Given this list of marker genes PAX6, MSX1, DCX, ZIC1, TUBB3, here is a description of the gene set: Human Gene Set: TESAR_ALK_AND_JAK_TARGETS_MOUSE_ES_D4_UP studied in species Mus musculus The application of human embryonic stem (ES) cells in medicine and biology has an inherent reliance on understanding the starting cell population. Human ES cells differ from mouse ES cells and the specific embryonic origin of both cell types is unclear. Previous work suggested that mouse ES cells could only be obtained from the embryo before implantation in the uterus. Here we show that cell lines can be derived from the epiblast, a tissue of the post-implantation embryo that generates the embryo proper. These cells, which we refer to as EpiSCs (post-implantation epiblast-derived stem cells), express transcription factors known to regulate pluripotency, maintain their genomic integrity, and robustly differentiate into the major somatic cell types as well as primordial germ cells. The EpiSC lines are distinct from mouse ES cells in their epigenetic state and the signals controlling their differentiation. Furthermore, EpiSC and human ES cells share patterns of gene expression and signalling responses that normally function in the epiblast. These results show that epiblast cells can be maintained as stable cell lines and interrogated to understand how pluripotent cells generate distinct fates during early development. from publication Tesar PJ, Chenoweth JG, Brook FA, Davies TJ, Evans EP, Mack DL, Gardner RL, McKay RD (PMID 17597760) Genes up-regulated in mES cells (mouse embryonic stem cells) after tratment with the ALK inhibitor SB-431542 and JAK inhibitor I.